The following is a description of a gene set: Microlissencephaly Severe microcephaly and lissencephaly with granular surfaces with immature cortical plate, reduced in thickness, with focal polymicrogyria and immature small neurons with rare processes, intermingled with a considerable number of glial elements. species: Homo sapiens Human Gene Set: HP_MICROLISSENCEPHALY, and this is the list of marker genes: NDE1, RNU4ATAC, RELN, CIT, KATNB1, KIF14